Given this list of marker genes DDRGK1, GUSB, EXTL3, GPC3, GSC, ALG9, INTU, SBDS, MATN3, PCYT1A, DYM, CFAP410 (NCBI Gene Id 755), TRPV4, COL11A1, GPX4, SRP54, CEP120, COL2A1, DNAJC21, FGFR3, GPC4, here is a description of the gene set: Narrow greater sciatic notch A narrowing of the sacrosciatic notch, i.e., the deep indentation in the posterior border of the hip bone at the point of union of the ilium and ischium. species: Homo sapiens Human Gene Set: HP_NARROW_GREATER_SCIATIC_NOTCH